Given this list of marker genes ABL1, CTNNB1, VEGFA, SIRT6, MDK, FGF2 (fibroblast growth factor 2), here is a description of the gene set: Any process that activates or increases the frequency, rate or extent of blood vessel branching. Human Gene Set: GOBP_POSITIVE_REGULATION_OF_BLOOD_VESSEL_BRANCHING studied in species Homo sapiens